The following is a description of a gene set: An abnormal shape of the vertebral bodies whereby the vertebral bodies are thick on one side and taper to a thin edge at the other. Human Gene Set: HP_VERTEBRAL_WEDGING Vertebral wedging species: Homo sapiens, and this is the list of marker genes: FANCC, PTCH2, CANT1, FN1, COL2A1, FZD2, POP1 (POP1 homolog, ribonuclease P/MRP subunit), SEC23A, CCN6, NPR2, PTCH1, IFITM5, SUFU, ARSB, FKBP10, MBTPS2, BGN, TRPV4, IFT43